The following is a description of a gene set: Any process that stops, prevents, or reduces the frequency, rate or extent of the directed movement of amino acids into, out of or within a cell, or between cells, by means of some agent such as a transporter or pore. Mouse Gene Set: GOBP_NEGATIVE_REGULATION_OF_AMINO_ACID_TRANSPORT studied in species Mus musculus, and this is the list of marker genes: Gabbr1 (gamma-aminobutyric acid type B receptor subunit 1), Trh, Il1rn, Il1b, Adora1, Rgs2, Htr1a, Slc43a1, Htr6, Grm7, Prkg1, Hrh3, Tnf, Slc15a1, Npy5r, Slc43a2, Arl6ip5, Abat, Htr1b, Rgs4, Lep